Given this list of marker genes TSPY1, SSH1, CGGBP1, HIPK2, SERPINA5, B3GALNT1, UTP25, SLC11A1, CUBN, TMCO6, BLK, DPH1, JMJD6, CBY1, GHRHR, CLDN4, ZBTB18, LYRM9, MLLT11, HMGCL, MORC2, SIX1, ETFDH, PHKA1, GPR19, THOC1, MYF5, NGF, MANBA, XCL1, MGMT, UTY, PRPH2, HOMER1, ZNF710, CSF2RB, NUP42, RIF1, IQSEC2, CDKN1B, BCKDK, FRMPD4, ICA1, XYLT1, NAT2, MYL5, ARHGEF12 (Rho guanine nucleotide exchange factor 12), RABGGTA, SMAD5, GABPB1, HIC2, TBXA2R, HERC3, TH, MPPED2, PCSK7, DDX23, FAM168B, MT1A, RER1, ZNF174, PTGER1, NMNAT2, PLCB4, E2F1, GDF11, KNTC1, PAK1, CACNA1E, CCNB1, SLC16A5, NCAPH2, NAA80, CCDC22, GGA3, GRIN1, TLX2, H4C9, PPIH, OMG, RNF216P1, UCKL1, PTGDR2, DFFA, DHX30, SPN, BCS1L, TOX4, PAX2, MYBPC3, ME3, GABBR1, BTC, GDF5, SERPINB10, AGTR2, PPARG, CLDN8, E2F4, IMP4, KAT8, BCL6, SUPT7L, PRRC1, CDK5, DDIT4, CHML, PIP, PSCA (NCBI Gene Id 90297), FCMR, POLD2, ZFYVE9, FOLR2, SCN8A, CTPS1, SEC16A, OCA2, ANGEL1, RDH11, FGF8, SLC16A2, MPDU1, MMP16, ESM1, TFR2, TERF2, CENPX, DCAF7, BBS4, PSMB8, MAD1L1, TAF1B, PPARD, HOXA9, PPFIBP2, SRGAP2, KRR1, GPD1, PMS2, MYB, SRPX2, BRS3, POU6F1, DHX57, COL11A2, ZNF135, MTM1, TRAC, PIGQ, LIN37, PMS2P3, PIAS3, ETFB, AGGF1, S1PR1, DCC, POLG, F2RL1, PTPRR (protein tyrosine phosphatase receptor type R), KYNU, INHBA, ERI3, MIR483, DUSP9, BTN3A3, CCL23, DYRK4, WT1-AS, SPOP, NDUFB7, ATF7, H2BC11, TXN2, EPX, CLDN7, CCNE1, ETS1, RUNX1T1, KATNB1, MAN2B2, MGRN1, RBM6, TTF2, SKIL, GTF2E1, WSCD1, B4GAT1, HRAS, PLA2G5, AKAP10, EDDM3A, HLA-DPB1, SLCO2A1, GCNT1, TYRP1, DYNC1I2 (dynein cytoplasmic 1 intermediate chain 2), EMG1, TRPC2 (transient receptor potential cation channel subfamily C member 2 (pseudogene)), WT1, AGO2, FABP2, DYRK2, CDR1, GSTT1, ATF1 (activating transcription factor 1), SBF1, HSPA4, IFT88, IGHV1-2, DLG4, CACNB2, AKT3, AMOT, SPAG9, PSMD13, ACHE, KIF14, CLCN6, here is a description of the gene set: Genes down-regulated in primary fibroblast cell culture after infection with HCMV (AD169 strain) at 1 h time point that were not down-regulated at the previous time point, 30 min. Human Gene Set: BROWNE_HCMV_INFECTION_1HR_DN The effect of human cytomegalovirus (HCMV) infection on cellular mRNA accumulation was analyzed by gene chip technology. During a 48-h time course after infection of human diploid fibroblasts, 1,425 cellular mRNAs were found to be up-regulated or down-regulated by threefold or greater in at least two consecutive time points. Several classes of genes were prominently affected, including interferon response genes, cell cycle regulators, apoptosis regulators, inflammatory pathway genes, and immune regulators. The number of mRNAs that were up-regulated or down-regulated were roughly equal over the complete time course. However, for the first 8 h after infection, the number of up-regulated mRNAs was significantly less than the number of down-regulated mRNAs. By analyzing the mRNA expression profile of cells infected in the presence of cycloheximide, it was found that a minimum of 25 mRNAs were modulated by HCMV in the absence of protein synthesis. These included mRNAs encoded by a small number of interferon-responsive genes, as well as beta interferon itself. Cellular mRNA levels in cytomegalovirus-infected cells were compared to the levels in cells infected with UV-inactivated virus. The inactivated virus caused the up-regulation of a much greater number of mRNAs, many of which encoded proteins with antiviral roles, such as interferon-responsive genes and proinflammatory cytokines. These data argue that one or more newly synthesized viral gene products block the induction of antiviral pathways that are triggered by HCMV binding and entry. from publication Browne EP, Wing B, Coleman D, Shenk T (PMID 11711622) species: Homo sapiens